The following is a description of a gene set: Any process that results in a change in state or activity of a cell (in terms of movement, secretion, enzyme production, gene expression, etc.) as a result of a glucagon stimulus. Mouse Gene Set: GOBP_CELLULAR_RESPONSE_TO_GLUCAGON_STIMULUS studied in species Mus musculus, and this is the list of marker genes: Gcgr, Cps1, Glp2r, Ass1, Gcg, Gnas, Glp1r, Prkaca, Gjb2, Prkar1a, Adcy8, Pck1